The following is a description of a gene set: part of: APC/C-mediated degradation of cell cycle proteins This event has been computationally inferred from an event that has been demonstrated in another species.<p>The inference is based on the homology mapping from PANTHER. Briefly, reactions for which all involved PhysicalEntities (in input, output and catalyst) have a mapped orthologue/paralogue (for complexes at least 75% of components must have a mapping) are inferred to the other species. Reactome Pathway: APC/C:Cdh1 mediated degradation of Cdc20 and other APC/C:Cdh1 targeted proteins in late mitosis/early G1 electronically inferred by orthology from the curated human pathway studied in species Mus musculus, and this is the list of marker genes: Psmb6, Ube2s, Ube2e1, Psmd12, Anapc15, Psmd6, Rps27a, Psmc6, Psmd13, Anapc2, Psmc5, Ube2c (ubiquitin-conjugating enzyme E2C), Psma3, Psmc3, Psma6, Psmd7, Psma7, Psma1, Psma5, Rb1, Psmd1, Fzr1, Anapc10, Ubb, Psmb7, Psma2 (NCBI Gene Id 19166), Psmc4, Psmb5, Psma4, Ube2d1, Anapc7, Aurkb, Psmb4 (NCBI Gene Id 19172), Cdc26, Psmc1, Plk1, Cdc23, Psmc2